The following is a description of a gene set: Mouse Gene Set: MIR_6418_5P Genes predicted to be targets of miRBase v22 microRNA mmu_miR_6418_5p in miRDB v6.0 with MirTarget v4 prediction scores > 80 (high confidence targets). from publication Chen Y, Wang X (PMID 31504780) studied in species Mus musculus, and this is the list of marker genes: Vamp2, Sipa1l1, Cxxc5, Tns1, Gltp, Ryr2, Pcmtd2, Ppp1r14bl, Isl1, Tmem198b, Krt84, Tcam1, Cldn17, 6430548M08Rik, Rad54b, Apcdd1, Rfk, Plec, Stam, Zfp579, Slc25a23 (solute carrier family 25 (mitochondrial carrier; phosphate carrier), member 23), Mtmr7, Npy, Cabp5, Icos, Hipk3, Ikbkg, Snx33, Htr1d, Senp1, Ciart, Tmem241, 2900026A02Rik, Kif3b, Awat2, B3gnt7, Ltv1, Sema3c, Cavin4, Sox1, Hnrnpdl, Khk, Hunk, Arhgap36 (NCBI Gene Id 75404), Fsbp, Retreg3, Mxd1 (MAX dimerization protein 1), Slitrk1, Lrrtm3, Ube2d2a, Klhl18, Vangl1, Tnfsf15, Zbtb16, Bicra, Orc5, Alox5ap, Dppa4, Ston2, Gclm, Mga, Zbtb44, Tnfsf11